The following is a description of a gene set: Human Gene Set: GOBP_POSITIVE_REGULATION_OF_PEPTIDE_SECRETION Any process that activates or increases the frequency, rate, or extent of peptide secretion. species: Homo sapiens, and this is the list of marker genes: CASR, BAD, OXCT1, GPRC6A, UCN, GPR68, SELENOT, BLK, PFKM, FFAR1, STX4, GPR27, RAC1 (Rac family small GTPase 1), PCK2, MLXIPL, PRKD1, ORAI1, DRD2, TARDBP (NCBI Gene Id 81927), FFAR4 (free fatty acid receptor 4), ILDR1, MCU, TRPM4, GLUD1, ADORA1, HIF1A, FGB, SCT, NLGN2, ABAT, TRPM5, RBP4, RAB8B, CFTR, GHRH, NADK, LRRC8A, RFX6, ADCY8, GABBR1, ITSN1, C2CD2L, APLN, MPC2, RAPGEF4, SOX4, NPY2R, PHPT1, PRKCE, PSMD9, BAIAP3, ISL1, TNFSF11 (NCBI Gene Id 8600), TRPA1, AIMP1, PFKFB2, PRKCA, TCF7L2 (transcription factor 7 like 2), TM7SF3, VSNL1, GPER1, PRKCB, SYBU, CRH, NKX6-1, RASL10B (RAS like family 10 member B), F2RL2, ABCC8, PLCB1, AACS, FFAR2, ACSL4, NR1H4, GHRHR, PRKAR1A, SERP1, TFR2, JAK2, CHRM3, PDX1, SIRT6, UCN3, GCG, OSBP, GRP (gastrin releasing peptide), ECRG4, GIP, NMU, DOC2B, SLC30A8, F2, MYRIP, GNA11, PLA2G6, INS, SLC2A2, PPARD, GPLD1, GHRL, PRKACA, ADCYAP1, GIPR, TUNAR, ANO1, IRS2, FGG, DYNLL1, S100A8 (S100 calcium binding protein A8), ITPR1, PPP3CB, GCK, CD38, SIRT3 (NCBI Gene Id 23410), HLA-DRB1, FGA, NR0B2, RPH3AL, PRKN, CAPN10, TRH, C1QTNF12, HFE, NNAT